Given this list of marker genes IFT140, PKD2, HLA-DRB1, TLR4, C1QA, CFI, LMX1B, HLA-DPB1, COL7A1, CD81, UBE2L3, EFEMP2, ALG9, ALG5, DGKE, APOL1, WDR19 (NCBI Gene Id 80203), C4B, INF2, LTBP1, GAPVD1, C3, NPHS2, DNASE1, PRKCD, ELN, BLK, IL12A, ZNFX1 (NCBI Gene Id 57169), KIAA0319L, ANLN, TREX1, PDCD1, IL23R, ETS1 (ETS proto-oncogene 1, transcription factor), CTLA4, MME, PRTN3 (proteinase 3), TRIM8, IRAK1, MMP1, NPHS1, ZMYM3, IL10, ZAP70, ERAP1, TNFSF4, CRB2, JAZF1, HOXA13, IFNGR1, SOX18, PTPN22, NUP107, PTPRO, STAT4, FCGR3B, IGHG1, ALDH18A1, FCGR2A, MECP2, WT1, PXK, COPA, GANAB, KLRC4, NUP205, LAGE3, VPS33A, TLR7, C4A (NCBI Gene Id 720), NUP37, CD151, MAGI2, MIF, HMOX1, IRF5, SPP1, CCR1, UBAC2, LAMB2, PKD1, ITGAM, COL4A5, LMNB2, COL4A4, IL6, SOCS1, ARPC5, HLA-DPA1, MEFV, LACC1, CR2 (NCBI Gene Id 1380), MED12, BANK1, SLC37A4, NUP160, FCGR2B, TAPBP, KIRREL1, DNAJB11, KCTD1, ANKFY1, COQ8B, XIAP, JAK1, MYH9, HLA-B, DNASE1L3, TBC1D8B, CFHR5, XDH, DAAM2, ALMS1 (ALMS1 centrosome and basal body associated protein), ARHGAP24, PLG, FBLN5, CD2AP, SLC7A7, MYH11, COL4A3, CASP10, ARHGDIA, PGM3, FASLG, NUP93, TRPC6, IL12A-AS1, NUP85, TNFAIP3, BNC2 (basonuclin zinc finger protein 2), BICC1, FAS, MYO1E, EMP2, KANK2, FOXP3, TNIP1, SAT1, UMOD, PLCE1 (phospholipase C epsilon 1), SMARCAL1, ACTN4, PAX2, NUP133, MYCN, DNASE2, here is a description of the gene set: species: Homo sapiens Nephritis Human Gene Set: HP_NEPHRITIS The presence of inflammation affecting the kidney.